The following is a description of a gene set: Vitamin B5 (pantothenate) metabolism Mouse Gene Set: REACTOME_VITAMIN_B5_PANTOTHENATE_METABOLISM species: Mus musculus, and this is the list of marker genes: Coasy, Pdzd11, Pank2, Vnn1, Slc5a6, Fasn, Ppcs, Pank4, Ppcdc, Dcakd, Pank1, Pank3, Aasdhppt, Slc25a16, Slc25a42